The following is a description of a gene set: studied in species Mus musculus A protein complex that contains two proteins (know in several organisms, including Drosophila, as NXF1 and NXF2) and is required for the export of the majority of mRNAs from the nucleus to the cytoplasm; localized in the nucleoplasm and at both the nucleoplasmic and cytoplasmic faces of the nuclear pore complex; shuttles between the nucleus and the cytoplasm. Mouse Gene Set: GOCC_NUCLEAR_RNA_EXPORT_FACTOR_COMPLEX, and this is the list of marker genes: Nxf7, Nxt1, Nxf3, Nxt2, Nxf1, Nxf2